Given this list of marker genes ATP2B4, SREK1IP1, ARMC10, VAPA, PANK1, LMX1A, KAT7, TMEM59, PLEKHA8, MACO1, SMARCA2, SECISBP2L, ZMPSTE24, CAMKK2, PTPRB, FBXO28, CDK13, PTGES3L, USP24 (ubiquitin specific peptidase 24), ZRANB1, NRXN1, ARGLU1, APTX, COL5A2, RASA1, FAM3B, GBP1, PEX12 (peroxisomal biogenesis factor 12), DGKB, PTGR2, KRT24, PHF6, SEPHS1, MLLT3, FMN1, TPST1, SNIP1, ATE1, TMEM41A, CSRNP3, NCKAP5, PGM3, PSD3, CASP7, SOX6, CCNF, ZBTB20, HPCAL4, ALPG, NXPH2, GOPC, PAPOLA, EIF5A2, CALU, AJAP1, HAND1, KSR2, CHFR, PTPN22, MTMR4, TCF4, FAM107B, CEP350, MED21, KDM4C, SYNC, JRK, POU5F1B, FAM131B, TMEM74, GLYR1, ARHGAP18, CD209, GJA5, F13A1, PRKAA2 (NCBI Gene Id 5563), CERS5, ZNF577, GATA2 (GATA binding protein 2), LDHB, RBFOX2 (NCBI Gene Id 23543), FLT1, C12orf71, ACTR2 (NCBI Gene Id 10097), KRT81 (NCBI Gene Id 3887), HOXD8, TXNDC8, ELAVL3, POU2F3, M6PR, SRF, SRSF4, KCNC1, CNOT7, SORCS1, SERF2, STAG1, TNFSF11, B4GAT1, CDC7, DAAM1, RTL9, ZHX1, RAB3B, TTK, UBE2G1, RPRM (NCBI Gene Id 89990), NAA25, POU5F1, KDM2B, here is a description of the gene set: Human Gene Set: MIR335_5P from publication Chen Y, Wang X (PMID 31504780) species: Homo sapiens Genes predicted to be targets of miRBase v22 microRNA hsa-miR-335-5p in miRDB v6.0 with MirTarget v4 prediction scores > 80 (high confidence targets).